Given this list of marker genes FADS3, ANO10, LEF1, RAB1B, AMOTL2, BCORL1, SLAMF8, ZNF335, LINC00698, DBT, C4orf3, PSD2, ABLIM3, ATG9A, C1orf159, IFIH1, FREY1, PLTP, GPR155, ZNF93, OCRL, WDTC1, TMEM123, IGKC, PDZK1P1 (PDZ domain containing 1 pseudogene 1), C4orf19, ALDH6A1, IGHV5-78, IL17A, TNFAIP8L1, MORF4L2-AS1, ITPR1, KCNH2, MS4A4A, FAS, PLEKHG3, RALGPS2, SLC6A6, CCDC148-AS1, CARD6, KYAT3, UNC5C, KCNA3, ADD1, MEF2A, LINC01743, NPFFR1, LYRM4-AS1, TANK, CCL25, PLEKHA2, ZNF461, ANKRD36BP2, DGCR2, GPR31, RIGI, EFNA5 (ephrin A5), PHKB, GRAMD1C, CDCA7L, RHOH, FICD, HDAC3, HPX, HP1BP3 (NCBI Gene Id 50809), PLXND1, ZNF224, RO60, JCHAIN, DENND2D, IKZF1 (NCBI Gene Id 55429), MLKL, VOPP1, ANKRD10, PRR36, RECQL4, ARHGEF3, PIM1, FAM76B, VAMP1, GPR146, PPP2R5D, UBE2E2, ENSG00000284691, HOXD4 (homeobox D4), MORC2-AS1, RAB40A, USP28, ZNF776, ADAMTS9, OMA1, RABGAP1L, RNF212B, LINC00879, ATP6V1A, SLC46A3, STK36, HIVEP1, ZNF345, GSN-AS1, ANKRD36, HSD17B3, RRAGB, KCNA5, LINC00466, KATNAL1, C2orf80, TP53I3, ATOSA, ARHGAP29, ENSG00000289161, N4BP2L2, PRDM2, F2RL2, NIBAN3, CHRNB1, SYP, RNFT2, ANKRA2 (NCBI Gene Id 57763), LINC00692, KLK11, TP53INP1, SLAMF6, TENT5D, C1GALT1, MYCBP, LAMC1, C2orf92 (NCBI Gene Id 730797, chromosome 2 open reading frame 92), PFKFB3, MYO1D, TTBK1, NBPF10, ABCA9, GPR6, NBPF4, CNTN1, OR7E24, PDE4B, CPNE8, C9orf152, ZNF107, LAMP3, STYXL2 (NCBI Gene Id 92235), KLF1, MARCHF1, PLSCR4, EMC10, CHRM2, FAM170B, MLIP, KCNQ1OT1, CREBRF, SLC5A3, CYLD, NACAD, PCMTD1, PRORSD1P, CDC20B, P2RX1, COL5A1, IGHV3OR16-13, CFAP46, ADAMDEC1 (NCBI Gene Id 27299, ADAM like decysin 1), NEIL1, DUSP8, CLDN2, DRP2, PSAP, LINC02577, THEMIS2, DPF1, TAAR8 (trace amine associated receptor 8), MYPN, KRTAP4-5, CHL1-AS2, RTL9, TMX4, ATP8A2, TGM5, BTNL9, TMOD2, CPLANE2, TMEM163, SESN3, BAZ2B, LINC02860, SEL1L3, TP53TG3HP, TEDC2-AS1 (TEDC2 antisense RNA 1), WDR45, here is a description of the gene set: Human Gene Set: GSE35543_IN_VIVO_NTREG_VS_IN_VITRO_ITREG_DN Genes down-regulated in T reg: in vivo versus in vitro. species: Homo sapiens Induced Treg (iTreg) cells are essential for tolerance and can be used therapeutically, yet their stability in vivo and mechanisms of suppression are unresolved. Here, we used a treatment model of colitis to examine the role of autologous IL-10 in iTreg cell function. Mice treated with IL-10+/+ iTreg cells in combination with IL-10–/– natural Treg (nTreg) cells survived and gained weight, even though iTreg cells were numerically disadvantaged and comprised just ~20% of all Treg cells in treated mice. Notably, ~85% of the transferred iTreg cells lost Foxp3 expression (ex-iTreg) but retained a portion of the iTreg transcriptome which failed to limit their pathogenic potential. The TCR repertoires of iTreg and ex-iTreg cells exhibited almost no overlap, which indicates that the two populations are clonally unrelated and maintained by different selective pressures. These data demonstrate a potent and critical role for iTreg cell produced IL-10 that can supplant the IL-10 produced by nTreg cells and compensate for the inherent instability of the iTreg population. from publication Schmitt EG, Haribhai D, Williams JB, Aggarwal P, Jia S, Charbonnier LM, Yan K, Lorier R, Turner A, Ziegelbauer J, Georgiev P, Simpson P, Salzman NH, Hessner MJ, Broeckel U, Chatila TA, Williams CB (PMID 23125413)